The following is a description of a gene set: studied in species Mus musculus Mouse Gene Set: GOBP_REGULATION_OF_AMINO_ACID_TRANSMEMBRANE_TRANSPORT Any process that modulates the frequency, rate or extent of amino acid transmembrane transport., and this is the list of marker genes: Slc7a5, Rgs4, Arl6ip5, Rgs2, Per2, Slc36a2, Itgb1, Cltrn, Arl6ip1, Slc43a1, Slc17a8, Arhgef11, Psen1, Agt (angiotensinogen), Arg1, Septin2, Slc43a2, Tnf, Arg2, Ace2, Slc38a1